Given this list of marker genes LINC01565, PRH1, CA6, APAF1, SLC28A1, AGFG2 (NCBI Gene Id 3268), GPR12, SCGB2A2, ICAM4, AFDN-DT, FOXI1, ELF5, CST5, FRMPD4, here is a description of the gene set: from publication Su AI, Cooke MP, Ching KA, Hakak Y, Walker JR, Wiltshire T, Orth AP, Vega RG, Sapinoso LM, Moqrich A, Patapoutian A, Hampton GM, Schultz PG, Hogenesch JB (PMID 11904358) Human Gene Set: SU_SALIVARY_GLAND High-throughput gene expression profiling has become an important tool for investigating transcriptional activity in a variety of biological samples. To date, the vast majority of these experiments have focused on specific biological processes and perturbations. Here, we have generated and analyzed gene expression from a set of samples spanning a broad range of biological conditions. Specifically, we profiled gene expression from 91 human and mouse samples across a diverse array of tissues, organs, and cell lines. Because these samples predominantly come from the normal physiological state in the human and mouse, this dataset represents a preliminary, but substantial, description of the normal mammalian transcriptome. We have used this dataset to illustrate methods of mining these data, and to reveal insights into molecular and physiological gene function, mechanisms of transcriptional regulation, disease etiology, and comparative genomics. Finally, to allow the scientific community to use this resource, we have built a free and publicly accessible website (http://expression.gnf.org) that integrates data visualization and curation of current gene annotations. Genes up-regulated specifically in human salivary gland tissue. studied in species Homo sapiens